Given this list of marker genes OFD1, IGHM, FNIP1 (folliculin interacting protein 1), RSPH4A, MUC5B, DSP (desmoplakin), MS4A1, TAP2, GCLC, SLC39A7, CD8A, ODAD2, SLC29A3, ZNF341, ATP11A, BLM, RIN2, BTNL2, WDR1, TAP1 (NCBI Gene Id 92050), PIK3R1, DNAH1 (dynein axonemal heavy chain 1), DNAAF4 (dynein axonemal assembly factor 4), ODAD1, IGLL1, EDNRA, DNAH5, DNAAF3, HMOX1, CCDC103, STX1A, MAGT1, MIF, DNMT3B, CD81, POLD3, NEK10, TPP2, SLC41A1, CTLA4, IRF9, KCNN4, DCTN4, SCNN1G, CXCR4, CFAP298, SFTPC, TP73, RFX5, CFAP300, MALT1, STK4, CARD10 (caspase recruitment domain family member 10), CCDC39, ICOS, RSPH1, GAS8, ODAD3, TNFRSF9, RIPK1, POLA1, DNAAF11, RTEL1, POLE, NFKB1, NME8, TNFRSF13C, ATM, SPAG1 (NCBI Gene Id 6674), C1QB, CFAP221, DPP9, NME5, SERPINA1 (serpin family A member 1), FAM13A, IL6ST (NCBI Gene Id 3572), GSTM3, DNAAF5, DNAL1, AGR2, FCGR2A, DNAH11, PI4KA, STX3, SLC11A1, SLC9A3, STAT1, RSPH3, STK36, CD19, GAS2L2, EMILIN1, IRF8, SASH3, RASGRP1, PTEN, PIK3CD, HFE, B2M, RSPH9, SCNN1B, SYK, SPI1, SCNN1A, POLD1, DNAAF2, TET2, LRRC8A, ELN, SLF2, DNAI2, NBN (nibrin), IRF2BP2 (interferon regulatory factor 2 binding protein 2), TTC12, CLCA4, ODAD4, HYDIN, ARL2BP, TGFB1, CD79B, IL21R, NFKB2, UNC119, FOXJ1 (NCBI Gene Id 2302), CARD11, DNAAF1, TERC, CCNO, DNAH9, CCDC40, SFTPA2, LAT, DNAAF6, FBLN5, SPEF2, CARMIL2, SLC6A14, RPGR, ZMYND10, BACH2, MPEG1, CFAP74, CCDC65, IGKC, CD79A (CD79a molecule), BRWD1, SLC34A2, DIAPH1, IGHG2, BLNK, TERT, CEACAM3, DNAI1, NDUFA6, CEACAM6 (NCBI Gene Id 4680), RAC2 (NCBI Gene Id 5880), TCF3, ALDH18A1 (aldehyde dehydrogenase 18 family member A1), CFTR, TNFSF12, PGM3 (phosphoglucomutase 3), BTK, STN1, MCIDAS, DOCK8, NCKAP1L, DRC1 (dynein regulatory complex subunit 1), DNAJB13, SFTPA1, ARHGEF1, HLA-DRB1, LRBA, SLC26A9, PARN, STAT3, CR2, ABCA3, LRRC56, TNFRSF13B (TNF receptor superfamily member 13B), here is a description of the gene set: Persistent abnormal dilatation of the bronchi owing to localized and irreversible destruction and widening of the large airways. species: Homo sapiens Bronchiectasis Human Gene Set: HP_BRONCHIECTASIS